Given this list of marker genes COL4A3, GPR4, PAX8, IRX2, FGF8, SEC61A1, PKD2, SLC22A1, NUP160, DLG1, HS3ST3B1, ILK, GDNF, HES5, WNT7B, ANGPT2, CTNNB1, STAT1, HOXB7, MAGED1, NOG, COL4A4, CTNNBIP1, FOXC1, ITGB3, HES1, TMEM59L, NOTCH3, HOXD11, HS3ST3A1, ADIPOQ, SALL1, TCF21, JAG1, NPHS1, NPHS2, FOXC2 (forkhead box C2), BMP2, CFLAR, GLI3, AQP11, GREB1L, UMOD, WNT9B, DCHS2, SMO, KIF26B, WNK4, TFAP2B, WWTR1, SMAD4, FOXJ1, ITGA3, ACTA2, LHX1, EDN1, MTSS1, PODXL, VANGL2, IQGAP1, EYA1 (NCBI Gene Id 2138), PKD1, FGF2, ANGPT1, EDNRB, LZTS2, PDGFB, WT1, CD2AP, PROM1, FOXD1 (NCBI Gene Id 2297), PTPRO, AQP1, MPV17, GZF1, HEYL, CALB1, SIX2, CD34, NOTCH1, MYC, PDGFRA, ACAT1, NID1, GATA3 (NCBI Gene Id 84828), SULF2, EGR1, BMP7 (NCBI Gene Id 655), BASP1, PBX1, TGFB1, SIX1, NPNT, PDGFRB, AHI1, SOX9, WNT4, NUP107, ENPEP (NCBI Gene Id 2028), PAX2, NUP85, KIRREL3, GREM1, AGTR2, IRX3, EXT1, GPC3 (NCBI Gene Id 6394), TEK, MEF2C, MYO1E (NCBI Gene Id 4643), SHH, ADAMTS16, SOX8, WNT1, LGR4, KLHL3, VEGFA, CITED1, SLC22A6, MIR125A, LAMB2, DCHS1, MAGI2, LAMA5, HS2ST1, LIF, PECAM1, WNT11, HOXA11, BMP4, FGF1, ERBB4, SERPINB7, BCL2, RET (ret proto-oncogene), PDGFD, TACSTD2, WNT6, PTCH1, YAP1, CD24, NOTCH2, PPP3CA, OSR1, COMT, EDNRA, AGT, DLL1, WNT2B, IRX1, HNF1B, PLCE1, IL6R, SULF1, PDGFA, AMPD2, ASXL1, KLF15, POU3F3, SIX4, NUP133, here is a description of the gene set: Human Gene Set: GOBP_NEPHRON_DEVELOPMENT studied in species Homo sapiens The process whose specific outcome is the progression of the nephron over time, from its formation to the mature structure. A nephron is the functional unit of the kidney.